Given this list of marker genes Nab1, Uqcr11, Ech1, Ndufa9, Hnrnpa1, Mrpl27, Hnrnph2, Snrpg, Tcf19, Sf3b5, Gtf2a2, Prpsap2, Csrp1, Cyba, Mrpl13, Gsr, Dbnl, Psme2, Uqcr10, Ppp2r5c, Cox6a1, Armcx2, Romo1, Dap3, Sec61g, Tagln2, Pigx, M6pr, Atp5f1e, Bud31, Snrpd2, Dap, Ckap5, Pold3, Psma5, Pcx, Timm8b, Relb, Nmt1, Rpp30, S100a6, Ccnd1, Guk1 (guanylate kinase 1), Ppp1r7, Ndufa2, Chrac1, Mrpl11, Mrpl18, S100a10, Snrpe, Ndufa3, Rbm14, Chmp2a, Micos13, Tmem205, Eif4ebp1, Cyrib, Txndc17, Dgcr6, Abcc1, Mrps18a, Slc35b2, Ppih, Erg28, Uqcrb, Lsm3, Hddc2, Lyrm2, Tomm5, Reep5, Mrps33, Ndufv3, Cyb5b, Ssna1, Elob, Plac9, Gstm5, Pqbp1 (NCBI Gene Id 631302), Cox5b, Coa6, Psat1, Lage3, Ubl5, Ndufa5, Pex7, Atp5po, Dbi, Cox7b (NCBI Gene Id 96903), Ndufb11, Ciao2a, Tsen34, Nudt16l1 (nudix hydrolase 16 like 1), Calb1, Cox16, Etfb, Elof1, Ppib, Naa38, Rbm3, Ndufs2, Uqcrc2, Dynlrb1, Vps29, Psma6, Park7, Cuedc2, B9d1, Ncbp2, Cat, BC005624, Pole3, Rex1bd, Ebp, Fmc1, Gpn1, Rab28, Mtmr9, Anxa2, Polr3k, Fibp, Mrpl23, Snx10, Anxa1, Acyp2, Psmg4, Dnajc15, Mrpl35, Atp5mk, Nacc2, Sem1, Lamtor5, Ndufb5, Smtn, Pmpcb, Gpx4, Commd1, Ndufb8, C1d, Mrpl52, Cetn3, Taf9, Coa3, Ndufa13, Mrpl45 (NCBI Gene Id 97774), Tmed3, Pdcd5, Cuta, Atp5mj (ATP synthase membrane subunit j), Snrnp27, Cd320, Prdx2, Emc6, Ifngr2, Ly6a, Pccb, Ccz1, Ilvbl, Lgals1, Fam3c, Sumo3, Ogfr, 0610010K14Rik, Nedd8, Tkt, Fkbp3, Dpm3, Atp5pf, Anapc13, Ndufc1, Lsm8, Pafah1b3, Ces1d, Csrp2, Hnrnpl, Selenof, Mrpl28, Mien1, H2az1, Esd, here is a description of the gene set: Genes co-regulated in uterus during a time course response to progesterone: SOM cluster 13. Human infertility and recurrent pregnancy loss caused by implantation defects are poorly understood. Hoxa-10-deficient female mice have severe infertility and recurrent pregnancy loss due to defective uterine implantation. Gene expression profiling experiments reveal that Hoxa-10 is an important regulator of two critical events in implantation: stromal cell proliferation and local immunosuppression. At the time of implantation, Hoxa-10 mediates the progesterone-stimulated proliferation of uterine stromal cells. Hoxa-10 mutants express a stromal cell proliferation defect that is accompanied by quantitative or spatial alterations in the expression of two cyclin-dependent kinase inhibitor genes, p57 and p15. Hoxa-10 deficiency also leads to a severe local immunological disturbance, characterized by a polyclonal proliferation of T cells, that occurs in place of the normal progesterone-mediated immunosuppression in the periimplantation uterus. from publication Yao MW, Lim H, Schust DJ, Choe SE, Farago A, Ding Y, Michaud S, Church GM, Maas RL (PMID 12554760) Mouse Gene Set: YAO_TEMPORAL_RESPONSE_TO_PROGESTERONE_CLUSTER_13 species: Mus musculus